Given this list of marker genes CLDN18, GPLD1, ACTB, SLC5A1, SLC26A6, SLC1A1, CSF2, SLC1A3, SLC1A2, EDN1, ABCG2, AQP8, ABCC2, EDNRB, OSTM1, SLC9A4, AQP1, CFTR, ABCC1, CLCNKA, AHCYL1, P2RY4, CLCNKB, CLDN19, P2RY6, BEST1, ITPR1, PKP1, SCNN1B, CXADR, ACTG1, RHBG, RHCG, CLCN7, ABCB1, SLC12A2 (NCBI Gene Id 6558), CLDN3, here is a description of the gene set: Human Gene Set: GOBP_TRANSEPITHELIAL_TRANSPORT The directed movement of a substance from one side of an epithelium to the other. species: Homo sapiens